Given this list of marker genes SCARB1, LDLRAP1, LIPG, LIPC, LCAT, CETP (NCBI Gene Id 1071), LDLR (NCBI Gene Id 3949), APOB, LPL, APOA1, PCSK9, APOE, APOC2 (apolipoprotein C2), ABCA1, ANXA2, APOA2, MTTP, here is a description of the gene set: Human Gene Set: WP_METABOLIC_PATHWAY_OF_LDL_HDL_AND_TG_INCLUDING_DISEASES studied in species Homo sapiens Metabolic pathway of LDL, HDL and TG, including diseases